The following is a description of a gene set: Any process that activates or increases the frequency, rate or extent of smooth muscle cell differentiation. studied in species Mus musculus Mouse Gene Set: GOBP_POSITIVE_REGULATION_OF_SMOOTH_MUSCLE_CELL_DIFFERENTIATION, and this is the list of marker genes: Pias1, Gper1, Tshz3, Sod2, Shh, Efemp2, Eng, Myocd, Kit, Notch4, Notch1, Tmsb4x, Sirt1, Notch2, Olfm2, Smarcd3 (NCBI Gene Id 78383), Tgfb1, Cth